Given this list of marker genes UBE2D1, BMPR1B, BMPR2, UBE2D3, BMP2, SMAD4, BMPR1A, ACVR2B, AMH, GREM2, GDF2, SMAD6, BMP10, SMAD5, FSTL1, INHA, TGFBR3, CER1, INHBA, SMURF1, ACVR2A, ACVRL1, AMHR2, SMAD7, NOG, SMAD1, SMURF2, SKI, ZFYVE16, CHRDL1, SMAD9, here is a description of the gene set: Reactome Pathway: Signaling by BMP species: Homo sapiens part of: Signaling by TGFB family members Bone morphogenetic proteins (BMPs) have many biological activities in various tissues, including bone, cartilage, blood vessels, heart, kidney, neurons, liver and lung. They are members of the Transforming growth factor-Beta (TGFB) family. They bind to type II and type I serine-threonine kinase receptors, which transduce signals through SMAD and non-SMAD signalling pathways. BMP signalling is linked to a wide variety of clinical disorders, including vascular diseases, skeletal diseases and cancer. BMPs typically activate BMP type I receptors and signal via SMAD1, 5 and 8. They can be classified into several subgroups, including the BMP2/4 group, the BMP5-8 osteogenic protein-1 (OP1) group, the growth and differentiation factor (GDF) 5-7 group and the BMP9/10 group. Most of the proteins of the BMP2/4, OP1 and BMP9/10 groups induce formation of bone and cartilage tissues in vivo, while the GDF5-7 group induce cartilage and tendon-like, but not bone-like, tissues. Members of the TGFB family bind to two types of serine-threonine kinase receptors, type I and type II. BMPs can bind type I receptors in the absence of type II receptors, but both types are required for signal transduction. The presence of both types dramatically increases binding affinity. The type II receptor kinase transphosphorylates the type I receptor, which transmits specific intracellular signals. Type I and type II receptors share similar structural properties, comprised of a relatively short extracellular domain, a single membrane-spanning domain and an intracellular domain containing a serine-threonine kinase domain. Seven receptors, collectively referred to as the Activin receptor-like kinases (ALK), have been identified as type I receptors for the TGFB family in mammals. ALKs are classified into three groups based on their structure and function, the BMPRI group (Bone morphogenetic protein receptor type-1A, ALK3, BMPR1A and Bone morphogenetic protein receptor type-1B, ALK6, BMPR1B), the ALK1 group (Serine/threonine-protein kinase receptor R3, ALK1, ACVRL1 and Activin receptor type-1, ALK2, ACVR1) and the TBetaR1 group (Activin receptor type-1B, ALK4, ACVR1B and TGF-beta receptor type-1, ALK5, TGFBR1 and Activin receptor type-1C, ALK7, ACVR1C). ALK1 group and BMPRI group activate SMAD1/5/8 and transduce similar intracellular signals. The TBetaR1 group activate SMAD2/3. BMPR1A and ACVR1 are widely expressed. BMPR1B shows a more restricted expression profile. ACVRL1 is limited to endothelial cells and a few other cell types. The binding specificities of BMPs to type I receptors is affected by the type II receptors that are present. Typically, BMP2 and BMP4 bind to BMPR1A and BMPR1B (ten Dijke et al. 1994). BMP6 and BMP7 bind strongly to ACVR1 and weakly to BMPR1B. Growth/differentiation factor 5 (BMP14, GDF5) preferentially binds to BMPR1B, but not to other type I receptors. BMP9 and BMP10 bind to ACVRL1 and ACVRL. BMP type I receptors are shared by other members of the TGFB family. Three receptors, Bone morphogenetic protein receptor type-2 (BMPR2), Activin receptor type-2A (ACVR2A) and Activin receptor type-2B (ACVR2B) are the type II receptors for mammalian BMPs. They are widely expressed in various tissues. BMPR2 is specific for BMPs, whereas ACVR2A and ACVR2B are shared with activins and myostatin. BMP binding and signalling can be affected by coreceptors. Glycosylphosphatidylinositol (GPI)-anchored proteins of the repulsive guidance molecule (RGM) family, including RGMA, RGMB (DRAGON) and Hemojuvelin (HFE2, RGMC) are coreceptors for BMP2 and BMP4, enhancing signaling. They interact with BMP type I and/or type II receptors and bind BMP2 and BMP4, but not BMP7 or TGFB1. BMP2/4 signalling normally involves BMPR2, not ACVR2A or ACVR2B. Cells transfected with RGMA use both BMPR2 and ACVR2A for BMP-2/4 signalling, suggesting that RGMA facilitates the use of ACVR2A by BMP2/4. Endoglin (ENG) is a transmembrane protein expressed in proliferating endothelial cells. It binds various ligands including TGFB1/3, Activin-A and BMP2/7. It inhibits TGFB-induced responses and enhances BMP7-induced responses. Mutations in ENG result in hereditary haemorrhagic telangiectasia (HHT1), also known as OslerWeberRendu disease, while mutations in ACVRL1 lead to HHT2, suggesting that they act in a common signalling pathway. BMP2 is a dimeric protein, having two receptor-binding motifs. One is a high-affinity binding site for BMPR1A, the other is a low-affinity binding site for BMPR2. In the absence of ligand stimulation, small fractions of type II and type I receptors are present as preexisting homodimers and heterodimers on the cell surface. Ligand-binding increases oligomerization. The intracellular domains of type I receptors have a characteristic GS domain (glycine and serine-rich domain) located N-terminal to the serine-threonine kinase domains. Type II receptor kinases are constitutively active in the absence of ligand. Upon ligand binding, the type II receptor kinase phosphorylates the GS domain of the type I receptor, a critical event in signal transduction by the serine/threonine kinase receptors. Activation of the TGFBR1 receptor has been studied in detail. The inactive conformation is maintained by interaction between the GS domain, the N-terminal lobe and the activation loop of the kinase. When the GS domain is phosphorylated by the type II receptor kinase, the TGFBR1 kinase is converted to an active conformation. Mutations of Thr-204 in TGFBR1 and the corresponding Gln in BMP type I receptors lead to their constitutive activation. The L45 loop, in the kinase domain of type I receptors, specifically interacts with receptor-regulated Smads (R-Smads). Neurotrophic tyrosine kinase receptor type 3 (NT-3 growth factor receptor, TrkC, NTRK3) directly binds BMPR2, interfereing with its interaction with BMPR1A, which inhibits downstream signalling. Tyrosine-protein kinase transmembrane receptor ROR2 and BMPR1B form a heteromeric complex in a ligand independent fashion that modulatesGDF5-BMPR1B signalling by inhibition of Smad1/5 signalling. Type I receptor kinases activated by the type II receptor kinases, phosphorylate R-Smads. R-Smads then form a complex with common-partner Smad (co-Smad) and translocate to the nucleus. The oligomeric Smad complexes regulate the transcription of target genes through interaction with various transcription factors and transcriptional coactivators or corepressors. Inhibitory Smads (I-Smads) negatively regulate the action of R-Smads and/or co-Smads. Eight different Smads have been identified in mammals. Smad1, Smad5 and Smad8 are R-Smads in BMP signalling pathways (BMP-specific R-Smads). Smad2 and Smad3 are R-Smads in TGFB/activin<br>signalling pathways. BMP receptors can phosphorylate Smad2 in certain types of cells. Smad1, Smad5 and Smad8 are structurally highly similar to each other. The functional differences between them are largely unknown. Smad4 is the only co-Smad in mammals, shared by both BMP and TGFB/activin signalling pathways. Smad6 and Smad7 are I-Smads.